The following is a description of a gene set: Expression microarray analysis identified over genes regulated during puberty in the mouse mammary gland. Most prominent were genes whose expression increased in parallel with pubertal development and remained high thereafter. Members of the Wnt, transforming growth factor-beta and oestrogen-signalling pathways were significantly overrepresented. Comparison to expression data from CITED1 knockout mice identified a subset of oestrogen-responsive genes displaying altered expression in the absence of CITED1. Included in this subset are stanniocalcin2 (Stc2) and amphiregulin (Areg). Chromatin immunoprecipitation revealed that ERalpha binds to oestrogen response elements in both the Stc2 and Areg genes in the mammary gland during puberty. Additionally, CITED1 and ERalpha localize to the same epithelial cells of the pubertal mammary gland, supporting a role for interaction of these two proteins during normal development. In a human breast cancer data set, expression of Stc2, Areg and CITED1 parallel that of ERalpha. Similar to ERalpha, CITED1 expression correlates with good outcome in breast cancer, implying that potential maintenance of the ERalpha-CITED1 co-regulated signalling pathway in breast tumours can indicate good prognosis. The 'TEB profile genes': down-regulated during pubertal mammary gland development specifically in the TEB (terminal end bud) structures. studied in species Mus musculus from publication McBryan J, Howlin J, Kenny PA, Shioda T, Martin F (PMID 17486082) Mouse Gene Set: MCBRYAN_TERMINAL_END_BUD_DN, and this is the list of marker genes: Gsn, Nrip1, Ets1 (NCBI Gene Id 330916), Coro1a, Phgdh, Lck